Given this list of marker genes PFN4 (profilin family member 4), DLD, SLC12A2, MTFR1, ONECUT2, CAMSAP2, MAP10, ERLIN2, GTF3C3, RBM14-RBM4, BRIP1, REL, PCDH17, HMGB2, MMEL1, PTN, ARID4A, DCUN1D5, ZKSCAN2, NCOA2, FAM13C, VCL, CCDC32, MSL2, DZIP1, SFPQ (NCBI Gene Id 6421), CDC14A, CREB3L2, FPR2, CEP44, RBM4, MMGT1, SLC9A9, ZDHHC13, FHIP2A, CHUK, CACNB4, PRORP, L3MBTL3, NDNF, ST6GALNAC3, PELI1, CEP128, TBC1D9, ACSL1, NEDD1, FAM120A, FBXW11, GULP1, GRIA3, HNMT, LAMP2, GABRB2, here is a description of the gene set: Human Gene Set: MIR374C_3P species: Homo sapiens from publication Chen Y, Wang X (PMID 31504780) Genes predicted to be targets of miRBase v22 microRNA hsa-miR-374c-3p in miRDB v6.0 with MirTarget v4 prediction scores > 80 (high confidence targets).